The following is a description of a gene set: species: Homo sapiens Human Gene Set: GOBP_METANEPHRIC_NEPHRON_DEVELOPMENT The process whose specific outcome is the progression of a nephron in the metanephros over time, from its formation to the mature structure. A nephron is the functional unit of the kidney., and this is the list of marker genes: SOX8, PDGFRA, TFAP2B, NPHS2, SMO, WNT4, STAT1, TCF21, PKD1, PDGFB, OSR1, HES1, CD34, SALL1 (NCBI Gene Id 6299), IRX2, LAMB2, SOX9, LIF, HES5, AQP1, PAX2, BMP4, IRX1, EGR1, PAX8, LGR4, GDNF, SIX2, ADIPOQ, KIF26B, PKD2, FOXD1, AGTR2, RET, WT1, WNT9B, CTNNB1, PDGFRB, GREM1, LHX1